Given this list of marker genes THADA, BAX, BAK1, RAP1GDS1, TGM2, ATP2A1, here is a description of the gene set: species: Homo sapiens Human Gene Set: GOBP_NEGATIVE_REGULATION_OF_ENDOPLASMIC_RETICULUM_CALCIUM_ION_CONCENTRATION Any process that decreases the concentration of calcium ions in the endoplasmic reticulum.